Given this list of marker genes Fus, Ncoa6 (nuclear receptor coactivator 6), Isl1 (NCBI Gene Id 16392), Foxl2, Prmt2, Pcna, Wbp2, Ncoa2, Arid5a, Ccdc62, Mms19, Strn, Parp1, Ncor1, Dcaf13, Lats1, Zfp366, Hsd17b10, Ncoa1, Src, Padi2, Cnot1, Pik3r1, Dnmt1, Ppid, Pparg, Med1, Dcaf1, Nsd1, Arrb1, Dnaaf4, Psmc3ip, Ctnnb1, Ddx54, Ppargc1a, Nrip1, Grm1, Ncoa3, Nkx3-1, Srarp, Lef1, Pagr1a, Ppargc1b, Rnf4, Tacc1, Lcor (NCBI Gene Id 73153), Trip4, Taf10, Wipi1, Pias2, Esr1, here is a description of the gene set: Binding to a nuclear estrogen receptor. studied in species Mus musculus Mouse Gene Set: GOMF_NUCLEAR_ESTROGEN_RECEPTOR_BINDING